The following is a description of a gene set: studied in species Homo sapiens Human Gene Set: GOBP_REGULATION_OF_LEUKOCYTE_TETHERING_OR_ROLLING Any process that modulates the frequency, rate or extent of leukocyte tethering or rolling., and this is the list of marker genes: ST3GAL4, SELP, FUT9, CCL25, CXCL12, FUT7, CCR2, SELE, CHST4, CHST2, CCL21, ITGA4, ELANE, CCL28, FUT4, GCNT1